Given this list of marker genes PFKP, PGAM2, NUDT17, ENO2, PGAM1, FOXK1, PFKL, ME1, ENO3, PGK1, TPI1, SLC25A18, MDH1B, GPI, PKM, GOT1, OGDH, MDH1, MDH2, GCK, HK3, GOT2 (NCBI Gene Id 2806), GPD2, BCL2L13, GPD1, ENO1, FOXK2, GPD1L, PFKM, NUDT12, PGK2, PC, VCP (valosin containing protein), HK1, SLC25A13, SLC25A22, NUDT13, SLC25A11, HK2, SLC25A12, here is a description of the gene set: Human Gene Set: GOBP_NADH_METABOLIC_PROCESS studied in species Homo sapiens The chemical reactions and pathways involving reduced nicotinamide adenine dinucleotide (NADH), a coenzyme present in most living cells and derived from the B vitamin nicotinic acid.